The following is a description of a gene set: species: Homo sapiens Any process that decreases the rate, extent or frequency of the process in which cardiac muscle adapts, with consequent modifications to structural and/or functional phenotypes, in response to a stimulus. Stimuli include contractile activity, loading conditions, substrate supply, and environmental factors. Human Gene Set: GOBP_NEGATIVE_REGULATION_OF_CARDIAC_MUSCLE_ADAPTATION, and this is the list of marker genes: MIR25, LMNA, APLNR, ERRFI1, MLIP, SMAD3, PPARG, ATP2B4, FOXO1, MIR214